The following is a description of a gene set: studied in species Mus musculus Human infertility and recurrent pregnancy loss caused by implantation defects are poorly understood. Hoxa-10-deficient female mice have severe infertility and recurrent pregnancy loss due to defective uterine implantation. Gene expression profiling experiments reveal that Hoxa-10 is an important regulator of two critical events in implantation: stromal cell proliferation and local immunosuppression. At the time of implantation, Hoxa-10 mediates the progesterone-stimulated proliferation of uterine stromal cells. Hoxa-10 mutants express a stromal cell proliferation defect that is accompanied by quantitative or spatial alterations in the expression of two cyclin-dependent kinase inhibitor genes, p57 and p15. Hoxa-10 deficiency also leads to a severe local immunological disturbance, characterized by a polyclonal proliferation of T cells, that occurs in place of the normal progesterone-mediated immunosuppression in the periimplantation uterus. Genes co-regulated in uterus during a time course response to progesterone: SOM cluster 7. Human Gene Set: YAO_TEMPORAL_RESPONSE_TO_PROGESTERONE_CLUSTER_7 from publication Yao MW, Lim H, Schust DJ, Choe SE, Farago A, Ding Y, Michaud S, Church GM, Maas RL (PMID 12554760), and this is the list of marker genes: HNRNPA2B1, CHERP, AMOTL2, LEPROT, ZFPM1, SNAI1, DDX3X (NCBI Gene Id 730543), TPD52L1, RAB7A, EIF4A1, MRPS26, MAIP1, EIF2S1, MRPL17, RREB1, PPP1R15B, RASIP1, HNRNPC, ANP32B, CDV3, CNN2, CRIP1, ZNF281, BRD2 (bromodomain containing 2), TAPBP, MIDN (NCBI Gene Id 94034), SOD2, EIF3J, GNB1, HSPA4, BRIX1, SULT1A1, PGLS, BCAT2, HRAS, CLDN3, MGAT2, FZD2, JAGN1 (NCBI Gene Id 84522), PTK2, PSMA2, REM1, MRPL43, ATP1A1, SLC25A48, PPM1G, FAM136A, ETF1, UBQLN2 (NCBI Gene Id 29978), MTERF3 (NCBI Gene Id 51001), ARL8B (ADP ribosylation factor like GTPase 8B), MAGOH, DDA1, NCDN, FOXA2, ANKRD40, SAR1B, CBX4, ARHGAP35, SERTAD1, ITGB1BP1, SCAMP2, KIF5B, COPS3, MT1F, WSB2, CDC34, EMC8, CNGA2, RAMP1, GANAB, TM2D2, ANXA3